Given this list of marker genes CKS2, NFKBIZ, CSRNP1, CLCF1, LBH, STARD4, SNUPN, USP53, CSF1, PLD1, HES4, SLCO4A1, PLAUR, OSGIN1, RAB21, PMAIP1, SLC3A2, NMRAL2P, RRN3P1, LINC-PINT, RIPK2, GADD45B, IL10, IL23A, RGCC, CCRL2, NR4A1, CHAC1, NOCT, DYRK3, SLC38A2, KLF6, ADTRP, PTP4A1, TSC22D2, FLT1, CDKN1A, PCF11, USP12, TFRC, ID2, ASPH, ZFC3H1, PLA1A, MAP3K8, TSLP, TXN, ZC3H12A, DUSP1, RIT1, GTF2A1, ZC3HC1, LIMS3, TMEM185B, ATP2B1-AS1, C11orf96, TMEM38B, CD274, TMEM88, ST3GAL6, MIR22HG, ADORA2A-AS1, MSANTD3, PIM1, LINC00299, COQ10B, PTS, FAM131A, NR4A2, IL6, SYNPO2, ADM, RGS1, LYSET, GLA, BANP, ETS2 (ETS proto-oncogene 2, transcription factor), HBEGF, GCNA, S1PR3, IL1A, HECW2, OSGIN2, GEM, CFLAR-AS1, STARD8, EGLN3, SNAPC1, SNX33, CYB5D1, JUN, RPGR, EIF2AK3, FOSL1, PLK3, INHBA, DTL, SELENOK, NSMAF, MIR3945HG, DUSP2, LRRC8B, SLC2A3, SLC19A2, BHLHE40, NRROS, PTGER4, PIM3, KLF10, NEU1 (neuraminidase 1), SGK1, RAB1A, MAFK, MOAP1, PHLDA2, PHACTR2, CCDC59 (coiled-coil domain containing 59), FERMT2, TLNRD1, MAPK6, OGT, NEDD4L, MMP10, RTP3, SCML1, HOMER1, TNFSF15, DUSP5, KLHL21, FBXO30, STX3, TP53BP2, NLRP3, RAPGEF2 (NCBI Gene Id 9693), HES1, GCLM, MIR155HG, ACSL3, SPRY2, SFR1, CCL18, NPC1, EDN1, PPP1R15B, ATP6V1H, KLHL6, CFLAR, FNIP2, ERRFI1, SIAH2, ABL2, GADD45A, GPRC5A, TNF, DNAJB4, SLC9B2, CREB5, EGR1, DDIT4, SNX9, IL36G, TCEAL9, N4BP2, RASGEF1B, SESN2, E2F7, SRXN1, IL36RN, RABGEF1, KDM7A-DT, MMP1, B3GNT2, DLGAP1-AS2, F8, ARL5B, CXCL2, SAV1, CCR7, IER3, CSF3, CXCL8, RYBP, DYNLT2B, SOCS3, DCSTAMP, IL18, SPAG9, RBBP8, NUP58, DENND4A, GNPDA1, SPAG5, TBC1D7, ZNF674-AS1, PTGS2, here is a description of the gene set: from publication Dower K, Ellis DK, Saraf K, Jelinsky SA, Lin LL (PMID 18292579) TREM-1 is an orphan immunoreceptor expressed on monocytes, macrophages, and neutrophils. TREM-1 associates with and signals via the adapter protein DAP12/TYROBP, which contains an immunoreceptor tyrosine-based activation motif (ITAM). TREM-1 activation by receptor cross-linking is pro-inflammatory, and can amplify cellular responses to Toll-like receptor (TLR) ligands such as bacterial lipopolysaccharide (LPS). To investigate the cellular consequences of TREM-1 activation, we have characterized global gene expression changes in human monocytes in response to TREM-1 cross-linking in comparison to and combined with LPS. Both TREM-1 activation and LPS up-regulate chemokines, cytokines, matrix metalloproteases, and PTGS/COX2, consistent with a core inflammatory response. However, other immunomodulatory factors are selectively induced, including SPP1 and CSF1 (i.e., M-CSF) by TREM-1 activation and IL-23 and CSF3 (i.e., G-CSF) by LPS. Additionally, cross-talk between TREM-1 activation and LPS occurs on multiple levels. While synergy in GM-CSF protein production is reflected in commensurate mRNA abundance, comparable synergy in IL-1b protein production is not. TREM-1 activation also attenuates the induction of some LPS target genes, including those that encode IL-12 cytokine family subunits. Whereas positive TREM-1 outputs are abolished by the PI3K inhibitor wortmannin, this attenuation is largely PI3K-independent. These experiments provide a detailed analysis of the cellular consequences of TREM-1 activation, and highlight some of the complexity in signal integration between ITAM- and TLR-mediated signaling. species: Homo sapiens Human Gene Set: GSE9988_ANTI_TREM1_AND_LPS_VS_CTRL_TREATED_MONOCYTES_UP Genes up-regulated in comparison of monocytes treated with anti-TREM1 and 5000 ng/ml LPS (TLR4 agonist) versus monocytes treated with control IgG.